Given this list of marker genes ACER1, ASAH2, SMPD2, SMPD1, SMPD4, SMPD3 (sphingomyelin phosphodiesterase 3), ACER2, ASAH1, here is a description of the gene set: studied in species Homo sapiens Human Gene Set: KEGG_MEDICUS_REFERENCE_HYDROLYSIS_OF_SPHINGOMYELIN Hydrolysis of sphingomyelin. Pathway ID: N00649. Pathway type: Reference. Pathway class: nt06014 Sphingolipid degradation. Pathway Definition from KEGG: Sphingomyelin -- SMPD -> Ceramide -- ASAH -> Sphingosine